Given this list of marker genes CHSY1, SCUBE3, DNMT3A, TBC1D2B, ANKRD11, TUBGCP2, RNF2, STAG1, HMGB3, ABCC9, ATRX, FREM1, GATAD2B (GATA zinc finger domain containing 2B), ALX3 (ALX homeobox 3), DOCK7, HRAS, here is a description of the gene set: Human Gene Set: HP_MISALIGNMENT_OF_INCISORS studied in species Homo sapiens Misalignment of incisors Misaligned incisor.